The following is a description of a gene set: from publication Chen Y, Wang X (PMID 31504780) studied in species Homo sapiens Human Gene Set: MIR711 Genes predicted to be targets of miRBase v22 microRNA hsa-miR-711 in miRDB v6.0 with MirTarget v4 prediction scores > 80 (high confidence targets)., and this is the list of marker genes: CREBRF, COL4A5, C14orf180, LARP1B, TET3, SMARCD1, DUSP5, MYD88, CDK5R1, PSMA4, ACVR2B, AK2, RPRD2, IL18BP, SYT1, ZBTB10, MEX3C, SKI, KRTAP20-3, HAPSTR1, NECAP1, FGF14, TK2, ZNF638, WNT4, DCAF10, ALAS2, NTRK3, TMEM230, RBSN, SLC36A4, ARMC1, PAK2, RGS5, BNIPL, SYNPO2, AP2B1, TBXA2R, TADA1, GATA2, C2CD2